The following is a description of a gene set: from publication Ding L, Getz G, Wheeler DA, Mardis ER, McLellan MD, Cibulskis K, Sougnez C, Greulich H, Muzny DM, Morgan MB, Fulton L, Fulton RS, Zhang Q, Wendl MC, Lawrence MS, Larson DE, Chen K, Dooling DJ, Sabo A, Hawes AC, Shen H, Jhangiani SN, Lewis LR, Hall O, Zhu Y, Mathew T, Ren Y, Yao J, Scherer SE, Clerc K, Metcalf GA, Ng B, Milosavljevic A, Gonzalez-Garay ML, Osborne JR, Meyer R, Shi X, Tang Y, Koboldt DC, Lin L, Abbott R, Miner TL, Pohl C, Fewell G, Haipek C, Schmidt H, Dunford-Shore BH, Kraja A, Crosby SD, Sawyer CS, Vickery T, Sander S, Robinson J, Winckler W, Baldwin J, Chirieac LR, Dutt A, Fennell T, Hanna M, Johnson BE, Onofrio RC, Thomas RK, Tonon G, Weir BA, Zhao X, Ziaugra L, Zody MC, Giordano T, Orringer MB, Roth JA, Spitz MR, Wistuba II, Ozenberger B, Good PJ, Chang AC, Beer DG, Watson MA, Ladanyi M, Broderick S, Yoshizawa A, Travis WD, Pao W, Province MA, Weinstock GM, Varmus HE, Gabriel SB, Lander ES, Gibbs RA, Meyerson M, Wilson RK (PMID 18948947) Human Gene Set: DING_LUNG_CANCER_MUTATED_RECURRENTLY Determining the genetic basis of cancer requires comprehensive analyses of large collections of histopathologically well-classified primary tumours. Here we report the results of a collaborative study to discover somatic mutations in 188 human lung adenocarcinomas. DNA sequencing of genes with known or potential relationships to cancer revealed more than 1,000 somatic mutations across the samples. Our analysis identified genes that are mutated at significantly high frequencies and thus are probably involved in carcinogenesis. The frequently mutated genes include tyrosine kinases, among them the EGFR homologue ERBB4; multiple ephrin receptor genes, notably EPHA3; vascular endothelial growth factor receptor KDR; and NTRK genes. These data provide evidence of somatic mutations in primary lung adenocarcinoma for several tumour suppressor genes involved in other cancers--including NF1, APC, RB1 and ATM--and for sequence changes in PTPRD as well as the frequently deleted gene LRP1B. The observed mutational profiles correlate with clinical features, smoking status and DNA repair defects. These results are reinforced by data integration including single nucleotide polymorphism array and gene expression array. Our findings shed further light on several important signalling pathways involved in lung adenocarcinoma, and suggest new molecular targets for treatment. species: Homo sapiens The lung adenocarcinoma TSP (tumor sequencing project) genes bearing recurrent somatic mutations., and this is the list of marker genes: KRAS, STK11, FLT4, TP53, EGFR, NRAS